Given this list of marker genes Tslp, Il1b, Erbb4, Erap1, Cd2ap, Il10, Il36a, Il23r, Cnot9, Irak4, Flrt1, Cdh5, Pycard, Rnf126, Ms4a1, Artn, Nrxn1 (NCBI Gene Id 68042), Il2, Ereg, Pik3r1, Pgf, Adam17, Pdgfra, Il12b, Jak2, Itgb3, Nrtn, Tollip, Il6st, Pdgfb, Csf3, Fgf14, Angpt2, Pdgfrb, Fgf16, Ceacam1, Snx4, Fyn, Pibf1, Grap (NCBI Gene Id 71520, GRB2-related adaptor protein), Il12rb1, Gata3, Sos1, Fgf18, Plscr1, Pdgfc, Itga5, Tlr9, Cntf, Fgf2, Trip6, Fgf8, Cd44 (CD44 antigen), Grem1, Fgf22, Angpt4, Socs5, Pspn, Timm50, Dab2ip, Fgf20, Pten, Fer, Fgf1, Frs3, Pdgfd, Glmn, Hbegf, Tgfa, Il9, Irak1, Cblc, Il7, Atxn2, Rasa1, Psen1, Lingo1, Il36rn, Il11, Il12a, Il1a, Nptn, Sla, Ern1, Fgf23 (NCBI Gene Id 64654), Efemp1, Fgf6, Snx1, Agr2, Gdnf, Il1f10, Snx2, Klb, Btc, Flrt2, Pdcl3, Il3, Il1rap, Fgf21, Nherf1, Ecm1, Kl, Yes1 (YES proto-oncogene 1, Src family tyrosine kinase), Ncstn, Il4, Epgn, Flrt3, Esm1, Vegfc, Fgf7, Grin2b, Myd88, Il1r1, Cadm4, Fgf12, Pdgfa, Arf4, Il21, App, Fgf3, Egf, Pigr, Tnk2, Frs2, Vegfa, Cd300lf, Fgf4, Angpt1, Il6, Vegfb, Tlr5, Csf2, Fgf15, Il6ra (interleukin 6 receptor, alpha), Rnf41, Plscr2, Lyn, Fgf5, Fgf10, Ptprj, Il1rn (interleukin 1 receptor antagonist), Ccdc88a, Ticam2 (TIR domain containing adaptor molecule 2), Sdcbp, Fgf9, Fam83b, Vav2, Nrg2, Il5, Fgf17, Vav3, Shc1, Grb2, Vegfd, Areg (NCBI Gene Id 11839, amphiregulin), here is a description of the gene set: studied in species Mus musculus Binding to a growth factor receptor. Mouse Gene Set: GOMF_GROWTH_FACTOR_RECEPTOR_BINDING